Given this list of marker genes IL21R (NCBI Gene Id 50615), CDC42SE1, RNF217, MFAP2, LRRC56, SOX12 (SRY-box transcription factor 12), MBP, STXBP5L, FBXW4, TRPT1, DYNLRB2, CREB3L1, CHD3 (chromodomain helicase DNA binding protein 3), CFP (NCBI Gene Id 5200), SLC25A28, ABCA8, CCDC157, MRTFA, BMPR2, PNPLA2, REEP2, TAX1BP1, CELA1, PRKD3 (protein kinase D3), PALD1, HPN, IDH2, ZNF704, CAMK2G, GALNT2, NRM, TCOF1, NFIC, TNFSF14, CRB3, SERPINF1, TBC1D24, GAB3, CHRNA1, TPP1, OGFRL1, ARHGAP9, FER, GAMT, ESAM, WDR13, UNC119, RPS6KC1, CLUAP1, ABHD14B, DTX4, MTFR2, CTSF, GABRR1, TMCO1, SH2D5, CALCRL, PRCP, PLD4 (phospholipase D family member 4), PTPN12, LRRC3, MAEA, CIMIP5, RNF24, EXOC6, CCNL1 (cyclin L1), KYAT1, SELENOF, LAIR1, DNMBP, SLC9A9, CCL5 (C-C motif chemokine ligand 5), GATM, ACRBP, MYCBP2, HAND1, RTP4, MGAT5, DDX3X, ECH1, KCNK12 (potassium two pore domain channel subfamily K member 12), CTBP2, HSPA12B, B2M, PAQR5, PRKCH, GSTO1, CBFA2T2, LGALS8 (galectin 8), ZNF148, LDB1, BCL2 (BCL2 apoptosis regulator), FKBP9 (FKBP prolyl isomerase 9), RAPGEF2, TIA1 (NCBI Gene Id 7072), CFAP20, ALDH7A1, ANXA4, KLHDC10, CLDN7, ARID4A, ARHGAP42, BCL2L2, TSC22D3, HSD17B11, METTL3, CD33, RBPJ, SUSD6, UVSSA, EID2 (NCBI Gene Id 163126), FANCD2OS, DPP7, PANK2, NTAQ1 (N-terminal glutamine amidase 1), ZIM3, CLEC4E, MORN4, DNAJC6, YIPF5, CD48, INTS6L, DEF8, DNAJC9, PFN1 (profilin 1), PLSCR1, MAP4K1, UBE2Q1 (ubiquitin conjugating enzyme E2 Q1), UMOD, PWWP2B, TTC3, GPRASP2, RCBTB2, NBEAL2, KLHDC8A, KLHL7, FZD7, SLC12A6, GRAMD1A, ADI1, RUFY2, TACC1, ECI2, AZI2, ICAM1, MAP3K20, DUSP2, MAPK7, DUSP5, GIMAP6, PPP1R1B, CYFIP2, ENG, ARHGEF4, RASA4, ITPRIPL2, DAGLB, IL31RA, MSRB2, MACROH2A2, ANXA2, CARM1, NOPCHAP1, GTF2IRD2, MTUS2, ADAMTS1, GRP, MAGED1, SHISA5, GTF3C1, JAK1, ATF7IP, HPSE, TBXAS1, SPMAP2L, IKBKG, DOCK7, NAGA, RECK, G6PD, MPEG1, SERPINA12, TTF1, ENC1, BTBD3, SMO, NCKAP1L, VIPR2, RETREG1, RAC2, TCEA2, CNN2, FBXO17, ZNF569, SGK3, ERN1, TSPAN2, DTNBP1, RNF220, GSE1, here is a description of the gene set: from publication Kim TD, Terwey TH, Zakrzewski JL, Suh D, Kochman AA, Chen ME, King CG, Borsotti C, Grubin J, Smith OM, Heller G, Liu C, Murphy GF, Alpdogan O, van den Brink MR (PMID 18178870) Transcriptional response of murine allogeneic T cells (B10.BR) after stimulation with different organ-derived (spleen, liver, peripheral and mesenteric lymph nodes) dendritic cells (C57BL/6) in vitro studied in species Homo sapiens Human Gene Set: GSE5503_MLN_DC_VS_SPLEEN_DC_ACTIVATED_ALLOGENIC_TCELL_UP Genes up-regulated in allogeneic T cells after stimulation with dendritic cells from: mesenteric lymph nodes (mLN) versus spleen.